The following is a description of a gene set: species: Homo sapiens Human Gene Set: HP_RETINAL_DYSPLASIA The presence of developmental dysplasia of the retina. Retinal dysplasia, and this is the list of marker genes: B3GALNT2, FKRP, FLNB, COL11A1, DAG1, INPP5E, FOXE3, RXYLT1, POMT1, NDP, COX7B, POMGNT1, TUBB, LARGE1, PDE6D (NCBI Gene Id 5147), KIF11, NDUFB11 (NADH:ubiquinone oxidoreductase subunit B11), B4GAT1, POMGNT2, POMT2, HCCS, FKTN, POMK, DNAJC21, COL4A1, CRPPA